Given this list of marker genes Ccl24, Ogn, Il16, Wnt5a, F2rl2, Angpt2, Apela, Il1a, Park7, Wnt10b, Ccl27a, Prl8a2, Spdye4b, Cntf, Esp38, Dll4, Ostn, Mtrnr2l7, Tnfsf12, Cd80, Inhbc, Esp23, Il23a, Prl3d1, Il25, Ccl19-ps6, Angpt1, Zfp106, Il27, Ccl20, Clec12a, Cxcl3, Esp6, Grem2, Esp4, Fgf6, Fgf7, Defb4, Pdyn, Inhbb, Prkce, Slit2, Itpripl1, Pmch, Gcg, Crlf1 (cytokine receptor-like factor 1), Prlh, Ebi3, Rabep1, Tg, Flrt2, Areg, Ifna7, Cxcl2, Thpo, Sema4b, Gm13275, Prok1, Gdf10, Wnt8a, Dpp4, Agt, Fam3c, Nbl1, Tnfsf13b, Ccl11, Bglap, Inhbe, Nppb, Xcl1, Fn1, Nrg3, Igf2, Cxcl17, Amelx, Hsp90ab1, Fgf9, Sema3a, Tnfsf13 (NCBI Gene Id 69583), Csf2, Cort, Tnfsf14, Il17f, Npff (NCBI Gene Id 54615), Lif, Prl2a1, Cmtm2b, Mstn, Angptl8, Bmp3, Dkk3, Mdk, Inha, Ntf5 (neurotrophin 5), Gnrh1 (gonadotropin releasing hormone 1), Pate4, Wnt9a, Bmp8a, Sfrp2, Avp, Prl7c1, Epha7, Cck, Fam3b, Tnf, Slurp2, Cdnf, Cxcl12, Grem1, Lilrb4b, Ccn6, Cmtm3 (CKLF-like MARVEL transmembrane domain containing 3), Prl8a8, Prl2b1, C3, Defb3, Ifna4, Pcsk9, Aimp1, Fasl, Il18, Pthlh, Dkk2, Gas6, Nectin2, Enho, Bag6, Lynx1, Ctf1, Esp36, Tafa5, Jak2, Fbn1, Sst, Tslp (NCBI Gene Id 53603), Ntf3, Clec11a, Bdnf, Edn1, Il36rn, Prl3a1, Tgfb1, Ecrg4, C1qtnf4, Dll1, Ccl8, Grn, Erfe, Ifna12, Retnlg, Psca (NCBI Gene Id 72373, prostate stem cell antigen), Gdf15, Copa, Cripto, Retnlb, Ppbp, Osm, Reg3g, Cd274, Agrp, App, Eda, Bmp2, Sct, Tgfb3 (NCBI Gene Id 21809), Esp1, Prl6a1, Esp22, Esp15, Cxcl5, Csf1, Cmtm2a, Esp3, Hspe1-rs1, Pglyrp1, Wfikkn1, Ifna1, Prl8a9, Prl3c1, Scgb3a1, Ins2, Inhba, Ccl2, Igsf1, Edn3, Gh, Cx3cl1, Ucn, Ly6g6d, Bglap2, Tnfsf9, Esp18, Il21, Stc2, Adipoq, Spp1 (NCBI Gene Id 20750), Jag1, Ctsg, Defb48, Lgals3, Gm44501, Dgkq, Ifna14, Mif, Sema6d, Ly6e, Ifna2, Sema5a, Il17d, Npy, Sema4a, Tmem35a, Gpi1, Il15, Il36a, Wnt4, Prl8a1, Pdgfb, Fgf3, Il17c, Gphb5, F2, Igf1, Il11, Apln (NCBI Gene Id 77874), Prl2c3, Il20, Hcrt, Defb14, Uts2b, Adcyap1 (adenylate cyclase activating polypeptide 1), Prrt1, Nppc (NCBI Gene Id 18159), Gdf6, Nxnl1, Lhb, Ly6g, Fshb (follicle stimulating hormone beta), Tac4, Prl3b1, Fgf1, Sema3g, Ly6m, Insl5 (NCBI Gene Id 23919), Hbegf, Fbrs, Gdf5, Reln, Tnfsf10, Ly6i, Fndc5, Tac1, Tmeff1, Ccl19-ps5, Ly6g6g, Nectin4, Tafa3, Retn, Wnt3, Esp34, Fst, Gm13276, Bmp5, Bmp1, Defb33, Apoa2, Hspa1a, Ccl19-ps1, Nrg2, Sectm1b, Cxcl10, Reg1, Slurp1, Igfbp2, Gkn1, Gm6040, Ifnk, C1qtnf9, Esp31, Ifne, Mill2, Gm13277, Fbn2, Ccn3, Lypd1, Gdf7, Il12b, Pomc, Fgf4, Nenf, Cxcl14, Prl3d2, Insl3, Ccl26, Ly6a, Epo, Il10, Reg3b, Wnt5b, Gast, Ambn, Ghrl, Sema3d, Il19, Bmp8b, Sema3f, Osgin1, Lrpap1, Ccl4, Ifna5, Prl5a1, Rabep2, Ifnb1, Prl8a6, Pdgfa, Ereg, Tafa1, Il36b, Flrt3, Hdgf, Saa3, Mill1, Ccl25, Efna5, Ccl21d, Trh, Sema6c, Lta, Hamp, Mrap2, Jag2, Il1b, Lgals1, Ifna16, Gpnmb, Il24, Il1f10, Il17b, Ly6c2, Tnfsf11, Dut, Wnt11, Fgf13 (NCBI Gene Id 14168), a, Prl2c2, Il6, Nrtn (neurturin), Gdf2, Cartpt, Sema4f, Tafa4, Il1rn, Esp24, Apob, Gm13283, Fgf20, Lefty2, Vegfb, Il17a, Fgf5, Dkk1, Angptl3, Bmp4, Iapp, Metrnl, Timp1, Ccl17, Fgf16, Ltbp1 (latent transforming growth factor beta binding protein 1), Nmb, Gmfg, Ccl21b, Sema6a, Cd320, Defb46, Prl2c5, Vegfa, Vegfc, Stc1 (NCBI Gene Id 20855), Ccl6, Il3 (interleukin 3), Ccl9, Wnt8b, Cmtm7, Ccl21a, Gm13272, Ifna13, Fgf2, Eng (endoglin), Hmgb1, Prl4a1, Rln1, Gdnf, Wnt9b, Metrn, Kng1, Ccn2, Prl, Clcf1, Btc, Nampt, Ccl21f, Ccl19-ps4, Fgf10, Npvf, C1qtnf12, Il4, Ly6c1, Wnt7a, Osgin2, Ptn, Alkal2, Ndp, Crh, Gip, Qrfp, Defb7 (NCBI Gene Id 246080), Hmgb2, Prl7d1 (NCBI Gene Id 18814), Cd70, Ccn5, Grp, Fgf11, Cd86, Gm13271 (NCBI Gene Id 435791), Wnt7b, Ifnab, Pth (parathyroid hormone), Klk1b4, Dand5 (DAN domain family member 5, BMP antagonist), Prl3d3 (prolactin family 3, subfamily d, member 3), Agrn, Il36g, Ly6g6e, Dkkl1 (dickkopf-like 1), Tgfb2, Lep, Egf, Il33, Hdgfl3, Gdf11, Ifna9, Bmp7, Mup20, Esp16, Colec10, Klk1b3, Sema3e (NCBI Gene Id 330043), Epgn, Ngf, Apoa1, Gdf3, Calcb (NCBI Gene Id 116903), Ifnl2, Adm2, Ccl22, Prl7a2, Defb6, Vgf, Cxcl15, Il9, Ttr, Spx, Fgf8, Il5, Ccl5 (C-C motif chemokine ligand 5), Pdgfd, Pspn, Fgf12, Sema4g, Ucn2, Hgf, Pf4, Spdye4a, Defb8, Cer1, Kng2, Wnt6, Fgf23, Sema4c, Fgf18, Il22b, Wnt2b (NCBI Gene Id 22414), Alkbh1, Sema4d, Vip, Reg3a, Ccl19, Retnla, Ltb, Ly6f, Lama5, Ucn3, Amh, Kitl, Tnfsf15, Nodal, Tafa2, Scg2, Tgfa, Il12a, Fgf22, Tnfsf8, Cklf, Cxcl11, Thbs4, Ly6g2, Ifna6, Galp, Gdf9, Defb47, Tnfsf4, Bmp6, Cxcl1, Lypd6, Insl6, Mia, Igfbp5 (NCBI Gene Id 98676), Il2, Vegfd (NCBI Gene Id 14205), Penk, Ulbp1, Prl2c1, Ifna15, Oxt, Cdc42ep2, Nppa, Pyy, Esp8, S100a4, Ppy, Fkbp1a, Flt3l, Ccl21e, Lypd6b, Bmp10, Zp3 (NCBI Gene Id 22788), Gpr15lg, Wnt3a, Crhr2, Clec12b, Artn, Wnt1, Ccl19-ps3, 3110082I17Rik, Pde4d, Prl7b1, Adm, Edn2, Csf3, Cmtm5, Ly6h, Nrros (negative regulator of reactive oxygen species), Cdk5, Prl7a1, Apoe, Cxcl16, Wfikkn2, Hamp2, Ccl12, Mmrn2, Sema6b, Il7, Wnt2, Adh7, Gfral, Angpt4, Tff1, Dkk4, Ccl28, Fgf17, Mup1, Gdf1, Ccl1, Ccl3, Cxcl9, Il22, Cmtm8, Il13, Sectm1a, Sema5b, Cxcl13, Manf, Cga, Efemp1, Lilrb4a, Ifnz, Sema3c, Cd40lg, Gfer, Fgf21, Ins1 (insulin I), Nrg4, Gpha2, Pdgfc, Msmp, Tshb, Crlf2, 6030468B19Rik, Il31, Lefty1, Ctf2, Izumo1, Gal, Ghrh, Wnt10a, Uts2, Gmfb, Il34, Ifna11, Sema7a, Pgf, Sema3b, Ifng, Lrrc32, Ptk2b, Rln3, Nrg1, Mrap, Bmp15, S100a7a, Ccl7, Alkal1, Fgf14, Defb5, Wnt16, Clu (NCBI Gene Id 28201), Ifnl3, Nts, Pnoc, Fgf15, Tnfsf18, here is a description of the gene set: Mouse Gene Set: GOMF_SIGNALING_RECEPTOR_REGULATOR_ACTIVITY Binds to and modulates the activity of a receptor. species: Mus musculus